The following is a description of a gene set: Mouse Gene Set: GOBP_POSITIVE_REGULATION_OF_THYMOCYTE_APOPTOTIC_PROCESS species: Mus musculus Any process that activates or increases the frequency, rate or extent of thymocyte death by apoptotic process., and this is the list of marker genes: Bbc3, Wnt5a, Trp53, Zc3h8, Adam8, Nfkbid